Given this list of marker genes Birc5, Dync2i1, Mzt1, Nlrp3, Dynlt2b, here is a description of the gene set: A microtubule organizing center found in interphase cells, which organize a longitudinal array of three to five MT bundles from the nuclear envelope during interphase. Each MT bundle is composed of two to seven MTs arranged in an antiparallel configuration, with the dynamic MT plus ends extending toward the cell tips and stable minus ends near the nucleus. studied in species Mus musculus Mouse Gene Set: GOCC_INTERPHASE_MICROTUBULE_ORGANIZING_CENTER